The following is a description of a gene set: Mouse Gene Set: GOMF_OXIDOREDUCTASE_ACTIVITY_ACTING_ON_PAIRED_DONORS_WITH_INCORPORATION_OR_REDUCTION_OF_MOLECULAR_OXYGEN Catalysis of an oxidation-reduction (redox) reaction in which hydrogen or electrons are transferred from each of two donors, and molecular oxygen is reduced or incorporated into a donor. species: Mus musculus, and this is the list of marker genes: Sqle, Moxd1 (NCBI Gene Id 74332), Cyp4a32, Kdm3b, Ptgis, Cyp2a5, Cyp2j5, Kmo, Tet1, Cyp4v3, Cyp26b1, Cyp2c55, Ptgs2, Cyp2j7, Cyp4x1, Akr1d1, Cyp2d11, Cyp1b1, Alkbh7, Akr1c21, Pam, Phf2, Cyp4f13, Dynll1, P4htm, Cyp39a1, Cyp51, P4hb, Egln1, Mical1, Cyp2j6, Cyp2a4 (cytochrome P450, family 2, subfamily a, polypeptide 4), Jmjd6, Cyp2a22, Alkbh5, Tet2, Fads6, Tyr, Cthrc1, Cyp3a11, Cyp2c68, Akr1c18 (aldo-keto reductase family 1, member C18), Cyp27a1, Cyp2f2, Cyp2c38, Cyp2d9, Cyp8b1, Cyp3a57, Cyp2b9, Hmox2, Fmo3, P4ha2, Scd2, Ogfod3, Cyp2c39, Kdm1a (lysine (K)-specific demethylase 1A), Th, Cyp3a41b (cytochrome P450, family 3, subfamily a, polypeptide 41B), Cyp46a1 (cytochrome P450, family 46, subfamily a, polypeptide 1), Cyp2r1, Cyp2c50, Cyp2j11, Cyp1a2, Mical3, Plod3, Cyp2s1, Cyp4a12a, Cyp2u1, Degs1l, Akr1c20, Uty, Coq7, Gm4847, Egln2, Cyp2c67, Cyp2g1, Cyp2e1, Cyp2c23, Tet3, Phyhd1, Akr1c6, P3h2, Cyp7b1, Fads2, Fa2h, Ogfod1, Fmo1, Degs2, Cyp26c1, Ptgs1 (prostaglandin-endoperoxide synthase 1), Cmah, Akr1c13, Cyp2j13, Kdm4a (NCBI Gene Id 52239), Cyp27b1, Phyh, Cyp4a10, Park7 (NCBI Gene Id 57320), Cyp2w1, Cyp2ab1, Cyp1a1, Hsp90ab1, Cyp17a1, Fto, Cyp2d10, Kdm5b, Ahr, Pcbd1, Bbox1, Hsp90aa1, Fmo4, Alkbh8, Plod1, Akt1, Cyp2a12, Jmjd7, Cyp4a31, Kdm4b, Cyp3a25, Cyp2c70, Cyp2d26, Cyp3a41a, Moxd2, Faxdc2, Cyp2b13, Cyp4f18, Fads2b, Cyp2j12, Dbh, Akr1c19, Kdm5c, Cyp11a1, Cyp2c65, Por, Fads3, Cyp2c54, Cyp21a1, Cyp20a1, Kdm5d, Alkbh6, Kdm5a (NCBI Gene Id 94042), Scd4, Cyp2c37, Calm1, Pah, Egln3, Cyp2d12, Tbxas1, Calm3, Alkbh3, Dohh, Fmo5, Cyp2b10, Kdm2b, Scd1, Fmo9, P3h3, P3h1, Nos1, Akr1c12, Fmo2, Riox1, Cyp4b1, Akr1cl, Gm4846, Cyp4f15, Cyp11b2, Cyp2c66, Cyp4a29, Cyp3a44, Agmo, P4ha1, Mical2, Fmo6, Cyp2c29, Kdm4c, Nos2, Cyp2c69, Calm2, Cyp2b19, Hspbap1 (NCBI Gene Id 66667), Kdm3a, Cyp4a12b, Cyp2d34, Coq6, Kdm1b, Alkbh4, Tph2, Cyp2j9, Jmjd4, Kdm7a, Fdx1, Cyp2d22, Nos3, Pcbd2, Cyp7a1, Akr1c14 (aldo-keto reductase family 1, member C14), Asph, Kdm2a, Tph1, Atp2b4, Ogfod2 (NCBI Gene Id 74767), Peds1, Alkbh1 (NCBI Gene Id 72618), Cyp4f40, Tyw5, Cyp2c40, Plod2, Hr, Hif1an, Msmo1, Cyp24a1, P4ha3, Kdm6b, Tpo, Tyrp1, Kdm6a, Cyp2b23, Cyp4a30b, Cyp3a13, Cyp4a14, Cyb5a, Rsbn1, Hmox1, Cyp4f14, Sc5d, Cyp19a1, Scd3, Phf8 (NCBI Gene Id 320595), Ch25h, Cyp11b1, Kdm4d, Alkbh2, Cyp3a59, Kdm8, Cyp2d40, Cyp26a1, Cyp3a16, Cyp2j8, Degs1, Cyp2t4, Riox2, Fads1